The following is a description of a gene set: Yellow/white lesions of the retina studied in species Homo sapiens Human Gene Set: HP_YELLOW_WHITE_LESIONS_OF_THE_RETINA, and this is the list of marker genes: PCYT1A, PDE6B, DUX4L1, CNGA1, SCAPER, DNMT3B, SPATA7, PRPF4, ARL2BP, XYLT1, EYS, PDE6G, ARL6, TREX1, ZFYVE26, NEK2, RPGRIP1, TUB, CERKL, UNC119, MAK, FAM111A, MERTK, FBLN5, CFHR1, TSPAN12, RBP3, BBS2, C1QTNF5, TULP1, TOPORS, FAM161A, TTC8, TUBB4B, NRL, ARL3, RGR, REEP6, MFRP, KIAA1549, RDH12, ZNF513, IMPG1, SNRNP200, RPE65, CFH, RD3, NEU1, TINF2, IQCB1, RHO, TIMP3, HMCN1, PRPF6, PRPH2, PCARE, IMPG2, RP9, ESPN, KIZ, TMEM98, GUCY2D, MAX, CNGB1, NMNAT1, CFI, RPGR, ALMS1, PRCD, IFT88, RP1, IFT140, CRX, EFEMP1 (NCBI Gene Id 399564), POMGNT1, ALDH3A2, SMCHD1, CRB1, POT1, RB1, SLC7A14, XYLT2, SEMA4A, CTC1, ELOVL4, ROM1 (retinal outer segment membrane protein 1), CFAP418, ARHGEF18, IDH3A, APOE, DUX4 (double homeobox 4), RP2 (RP2 activator of ARL3 GTPase), PROM1, RDH5, RLBP1, NR2E3, USH2A, CFHR3, KLHL7, CEP290, DHX38, DHDDS, HGSNAT, CA4, IDH3B (isocitrate dehydrogenase (NAD(+)) 3 non-catalytic subunit beta), GUCA1B, IFT172, FRG1, PRPF31, AGXT, NDP, AIPL1 (aryl hydrocarbon receptor interacting protein like 1), IMPDH1, USP45, AHR, ZNF408, GDF6, AGBL5, PLA2G5, PRPF8, BBS1, FSCN2, SAG, ABCA4, PDE6A, BEST1, RP1L1, FZD4, KCNJ13, PRPF3, CLRN1 (NCBI Gene Id 7401), CDHR1, CNGB3, CC2D2A, LRP5, LCA5 (NCBI Gene Id 30828), AHI1, CTNNA1, OFD1, GUCA1A, LRAT, ABCC6